The following is a description of a gene set: part of: Integrin signaling Integrin signaling is linked to the MAP kinase pathway by recruiting Grb2 to the FADK1/SRC activation complex. studied in species Homo sapiens Reactome Pathway: GRB2:SOS provides linkage to MAPK signaling for Integrins, and this is the list of marker genes: SRC, GRB2, ITGA2B, FN1, VWF, APBB1IP, PTK2, TLN1, FGA, RAP1B, RAP1A, ITGB3, SOS1, FGG, FGB